Given this list of marker genes EP300, ESCO1, KAT2A, ING5, NAA16, NAA20, FOXO1, SPHK1, GTF2B, SIRT1, DIP2A, XBP1, CEP295, KAT5, MAGEA2B, HAT1 (NCBI Gene Id 8520), NAT8B, DSCC1 (NCBI Gene Id 79075), KAT2B, NAA60, ATAT1, NAA10, CREBBP, AANAT, KAT7, NAA50, BMAL1, NAT8, NAA80, KLF15, NAT10, ING4, NAA11, BAG6, ESCO2, NAA15, FAM161A, MAGEA2, CLOCK, DIP2B, BLOC1S1, KAT6A, here is a description of the gene set: species: Homo sapiens Human Gene Set: GOBP_PROTEIN_ACETYLATION The addition of an acetyl group to a protein amino acid. An acetyl group is CH3CO-, derived from acetic acid.